The following is a description of a gene set: from publication Wang Y, Klijn JG, Zhang Y, Sieuwerts AM, Look MP, Yang F, Talantov D, Timmermans M, Meijer-van Gelder ME, Yu J, Jatkoe T, Berns EM, Atkins D, Foekens JA (PMID 15721472) BACKGROUND: Genome-wide measures of gene expression can identify patterns of gene activity that subclassify tumours and might provide a better means than is currently available for individual risk assessment in patients with lymph-node-negative breast cancer. METHODS: We analysed, with Affymetrix Human U133a GeneChips, the expression of 22000 transcripts from total RNA of frozen tumour samples from 286 lymph-node-negative patients who had not received adjuvant systemic treatment. FINDINGS: In a training set of 115 tumours, we identified a 76-gene signature consisting of genes for patients positive for oestrogen receptors (ER) and genes for ER-negative patients. This signature showed 93% sensitivity and 48% specificity in a subsequent independent testing set of 171 lymph-node-negative patients. The gene profile was highly informative in identifying patients who developed distant metastases within 5 years (hazard ratio 5.67), even when corrected for traditional prognostic factors in multivariate analysis (5.55). The 76-gene profile also represented a strong prognostic factor for the development of metastasis in the subgroups of 84 premenopausal patients (9.60), 87 postmenopausal patients (4.04), and 79 patients with tumours of 10-20 mm (14.1), a group of patients for whom prediction of prognosis is especially difficult. INTERPRETATION: The identified signature provides a powerful tool for identification of patients at high risk of distant recurrence. The ability to identify patients who have a favourable prognosis could, after independent confirmation, allow clinicians to avoid adjuvant systemic therapy or to choose less aggressive therapeutic options. Genes whose expression in primary ER(+) breast cancer tumors positively correlates with developing distant metastases. studied in species Homo sapiens Human Gene Set: WANG_METASTASIS_OF_BREAST_CANCER_ESR1_UP, and this is the list of marker genes: CBX3, PLK1, PGAP6, CENPU, PPP1CC, H4C8, GTSE1, PSMC2, ZCCHC8, SMC4, SUPT16H, POLQ, CCNE2, UCKL1, EEF1A2, KPNA2, NCAPG2, MYRF, YIF1A, ATAD2, FEN1, HDGFL3